Given this list of marker genes CHRD, STIL, CLUAP1, NODAL, CDK20, DZIP1L, GLI2, FOXB1, CBY1, COBL, FERD3L, here is a description of the gene set: The progression of the floor plate over time from its initial formation until its mature state. Human Gene Set: GOBP_FLOOR_PLATE_DEVELOPMENT species: Homo sapiens